The following is a description of a gene set: Mouse Gene Set: GOMF_FOLIC_ACID_TRANSMEMBRANE_TRANSPORTER_ACTIVITY Enables the transfer of folic acid (pteroylglutamic acid) from one side of a membrane to the other. Folic acid is widely distributed as a member of the vitamin B complex and is essential for the synthesis of purine and pyrimidines. studied in species Mus musculus, and this is the list of marker genes: Slc19a3, Slc19a1, Pdpn, Slc46a1, Slc25a32